Given this list of marker genes FGF10, FGF1, FRS2, PLCG1, FGF3, PTPN11 (protein tyrosine phosphatase non-receptor type 11), HRAS, FGF5, FGF8, KRAS, GAB1, PIK3R1, FGF18, GRB2, FGF9, FGF7, FGF17, NRAS, FGF6, SHC1, FRS3, FGF16, FGFR2 (NCBI Gene Id 2263), FGF2, FGF23, SOS1, PIK3CA, FGF22, FGF4, FGF20, here is a description of the gene set: part of: Signaling by FGFR2 Reactome Pathway: Downstream signaling of activated FGFR2 Signaling via FGFRs is mediated via direct recruitment of signaling proteins that bind to tyrosine auto-phosphorylation sites on the activated receptor and via closely linked docking proteins that become tyrosine phosphorylated in response to FGF-stimulation and form a complex with additional complement of signaling proteins. <br><br>The activation loop in the catalytic domain of FGFR maintains the PTK domain in an inactive or low activity state. The activation-loop of FGFR1, for instance, contains two tyrosine residues that must be autophosphorylated for maintaining the catalytic domain in an active state. In the autoinhibited configuration, a kinase invariant proline residue at the C-terminal end of the activation loop interferes with substrate binding while allowing access to ATP in the nucleotide binding site.<br>In addition to the catalytic PTK core, the cytoplasmic domain of FGFR contains several regulatory sequences. The juxtamembrane domain of FGFRs is considerably longer than that of other receptor tyrosine kinases. This region contains a highly conserved sequence that serves as a binding site for the phosphotyrosine binding (PTB) domain of FRS2. A variety of signaling proteins are phosphorylated in response to FGF stimulation, including Shc, phospholipase-C gamma and FRS2 leading to stimulation of intracellular signaling pathways that control cell proliferation, cell differentiation, cell migration, cell survival and cell shape. studied in species Homo sapiens